The following is a description of a gene set: Human Gene Set: CASP3_TARGET_GENES species: Homo sapiens Genes containing one or more binding sites for (CASP3) in their promoter regions (TSS -1000,+100 bp) as identified by GTRD version 20.06 ChIP-seq harmonization. from publication Yevshin I, Sharipov R, Kolmykov S, Kondrakhin Y, Kolpakov F (PMID 30445619), and this is the list of marker genes: MT-TH, MT-TM, MT-TL2, MT-ND2, MT-TS2, MT-CO1, MT-TI, MT-TP, LINC01754, MT-RNR1, MT-TF, MT-ND5, MT-CYB, MT-TQ, MT-TW